The following is a description of a gene set: Any process that stops, prevents, or reduces the frequency, rate or extent of kinase activity, the catalysis of the transfer of a phosphate group, usually from ATP, to a substrate molecule. species: Homo sapiens Human Gene Set: GOBP_NEGATIVE_REGULATION_OF_KINASE_ACTIVITY, and this is the list of marker genes: CHMP6, TSG101, PTPRC, MEN1, NPM1, MAPK8IP1, CORO1C, DEPTOR, CEP43, RTRAF, CDKN1C, DBNDD2, GSKIP, AIDA, ACP4, PTPN1, SNX6, RGS14, NPPA, DEFB114, PAQR3, CDKN2A, TAF7, ADARB1, DUSP7, NPRL2, PPM1E, APC, DNAJA1, ITGB1BP1, CDK5RAP1, STK38, SRCIN1, PDCD4, CDKN1A, PRDX3, PAK2, MVP, VPS25, SERPINB3, GPRC5A, HIPK3, THY1, SOCS5, CEACAM1, ADAR, PTPRJ, PYCARD, PRKCH, ZFYVE28, LATS1, AGT, CEP85, MYCNOS, CDKN1B, PTK6, APOE, GADD45A, HEG1 (heart development protein with EGF like domains 1), RB1, MIDN, PTPN22, AKT1S1, CHP1 (NCBI Gene Id 11261), ADIPOQ, HNRNPU, RASIP1, TRIM27, PKIA, ERRFI1, CDK5RAP3, MACROH2A1, TARBP2, YWHAG, WARS1, DUSP1, GCKR, INCA1, ZGPAT, PRKN, SFN, SOCS4, LATS2, TFAP4, LYN, CD300A, PPIA (NCBI Gene Id 5478)